The following is a description of a gene set: species: Mus musculus Mouse Gene Set: REACTOME_REGULATION_OF_LOCALIZATION_OF_FOXO_TRANSCRIPTION_FACTORS Regulation of localization of FOXO transcription factors, and this is the list of marker genes: Ywhaq, Akt3, Foxo4, Ywhaz, Ywhab, Ywhag, Foxo6, Foxo1 (NCBI Gene Id 99758), Foxo3, Akt2, Akt1, Sfn